Given this list of marker genes SOX4, NKX2-2 (NK2 homeobox 2), MCM10, CDK5R1, HMGB3, TMEFF1, ZFP69B, ATAT1, LPAR4, BCOR, KAT7, PAK5, HDAC2, SEZ6L, CASK, IL1RAPL1, ZNF184, MYB, PDE10A, MMP15, GRID2, CHD7, CDC25A, DPF1, MAP2, CRMP1, RALGPS1, SEC61A2, ADGRL3, YPEL1, LRRTM4, RUFY3, TMCC1, DPP6 (NCBI Gene Id 653748), NR0B1, SLCO5A1, DNM3, EPHB1, CLASP2 (NCBI Gene Id 440948), SATB1 (SATB homeobox 1), GSK3B, DBN1 (drebrin 1), SCN3A, SOX10, MLLT11, GNG4, ERBB3, NCALD, FHOD3, SPTBN2, E2F3, MMP16, FERMT1, CSPG5, MIR9-1HG, PAK3, FXYD6, NRXN1, SCG3, WASF1, DCX, EPB41, KLRK1, PAFAH1B3, CAMSAP2, MYO10, TTYH1, JADE3, NOL4, KIF21B, DUSP26, RAP2A, DCAF7, SLC1A1, PCDH11Y, ATP1A3, CBX1, KLRC4, NLGN3, HOXD3, MATR3, CDKN1B, CA10, ZNF821, TMSB15A, KDM1A, TTC3, PLAAT1, RBPJ, CDC7, BCAN, MPPED2, FLRT1, TMEM35A, PPM1D, ZC4H2, FAM110B, CNTN1, TSPAN3, ZNF804A, MYT1, GRIA2 (NCBI Gene Id 2891), MAPT, CKB, REXO5, OLIG2, CSNK1E, ARHGEF9, ADGRB3, ALCAM, JPT1, LRP6, STMN1, BCL7A, DGKI, FBXO21, AMOTL2, ATAD5, PFN2, ZEB2, TAF5, NCAM1, GABRA3, C1QL1, PCDH11X, REEP1, MTSS1, PODXL2, TOX3, ZNF286A, GPM6A, TOP2B, PLCB4, CELF3, GADD45G, PELI1, SOX11, ZNF510, CXXC4, PHLPP1, DLL3, CLGN, ASCL1, RAB33A, SRGAP3, VAX2, SORCS3, PURG, FGF9, GSTA4, RAD21, P2RX7, KLRC3 (killer cell lectin like receptor C3), VEZF1, MAST1, TOPBP1, RALGPS2, STMN4, SOX2, ACTR1A, CRB1, DPYSL4, MVB12B (NCBI Gene Id 89853), CILK1, INAVA, ARHGAP33, GPR17, RNFT2, BEX1, ZNF711, NRXN2, PPM1E, MARCKS, ZNF248, ABAT, MARCKSL1, NKAIN1, here is a description of the gene set: from publication Verhaak RG, Hoadley KA, Purdom E, Wang V, Qi Y, Wilkerson MD, Miller CR, Ding L, Golub T, Mesirov JP, Alexe G, Lawrence M, O'Kelly M, Tamayo P, Weir BA, Gabriel S, Winckler W, Gupta S, Jakkula L, Feiler HS, Hodgson JG, James CD, Sarkaria JN, Brennan C, Kahn A, Spellman PT, Wilson RK, Speed TP, Gray JW, Meyerson M, Getz G, Perou CM, Hayes DN, Cancer Genome Atlas Research Network (PMID 20129251) The Cancer Genome Atlas Network recently cataloged recurrent genomic abnormalities in glioblastoma multiforme (GBM). We describe a robust gene expression-based molecular classification of GBM into Proneural, Neural, Classical, and Mesenchymal subtypes and integrate multidimensional genomic data to establish patterns of somatic mutations and DNA copy number. Aberrations and gene expression of EGFR, NF1, and PDGFRA/IDH1 each define the Classical, Mesenchymal, and Proneural subtypes, respectively. Gene signatures of normal brain cell types show a strong relationship between subtypes and different neural lineages. Additionally, response to aggressive therapy differs by subtype, with the greatest benefit in the Classical subtype and no benefit in the Proneural subtype. We provide a framework that unifies transcriptomic and genomic dimensions for GBM molecular stratification with important implications for future studies. studied in species Homo sapiens Human Gene Set: VERHAAK_GLIOBLASTOMA_PRONEURAL Genes correlated with proneural type of glioblastoma multiforme tumors.